Given this list of marker genes APCDD1, FFAR2 (free fatty acid receptor 2), HP, PPARG, RETN, VNN3P, RARRES2, CEBPA, ADCYAP1R1, CYP2F1 (NCBI Gene Id 1572), AOC3, FABP4, PANK3, SULT1A1, MC2R, ADRB3, AGT, LUM, SORT1, here is a description of the gene set: from publication Vernochet C, Peres SB, Davis KE, McDonald ME, Qiang L, Wang H, Scherer PE, Farmer SR (PMID 19564408) studied in species Mus musculus Genes up-regulated during adipogenic differentiation of 3T3-L1 cells (preadipocyte) and down-regulated by troglitazone. Human Gene Set: VERNOCHET_ADIPOGENESIS White adipose tissue (WAT) stores energy in the form of triglycerides, whereas brown tissue (BAT) expends energy, primarily by oxidizing lipids. WAT also secretes many cytokines and acute-phase proteins that contribute to insulin resistance in obese subjects. In this study, we have investigated the mechanisms by which activation of peroxisome proliferator-activated receptor gamma (PPARgamma) with synthetic agonists induces a brown phenotype in white adipocytes in vivo and in vitro. We demonstrate that this phenotypic conversion is characterized by repression of a set of white fat genes (visceral white), including the resistin, angiotensinogen, and chemerin genes, in addition to induction of brown-specific genes, such as Ucp-1. Importantly, the level of expression of the visceral white genes is high in mesenteric and gonadal WAT depots but low in the subcutaneous WAT depot and in BAT. Mutation of critical amino acids within helix 7 of the ligand-binding domain of PPARgamma prevents inhibition of visceral white gene expression by the synthetic agonists and therefore shows a direct role for PPARgamma in the repression process. Inhibition of the white adipocyte genes also depends on the expression of C/EBPalpha and the corepressors, carboxy-terminal binding proteins 1 and 2 (CtBP1/2). The data further show that repression of resistin and angiotensinogen expression involves recruitment of CtBP1/2, directed by C/EBPalpha, to the minimal promoter of the corresponding genes in response to the PPARgamma ligand. Developing strategies to enhance the brown phenotype in white adipocytes while reducing secretion of stress-related cytokines from visceral WAT is a means to combat obesity-associated disorders.